Given this list of marker genes CRHBP, ACOX3, GBP4, CDCA7L, PDCD4-AS1, SVIP, CYFIP2, LAPTM4B, DNMT3B, MSH2, TRBC2, LRRC61, MAP4K2, PIGQ, GMDS-DT (NCBI Gene Id 100508120), RASD1, APP, LINC02573, MED9, NUP107, MZB1, EXT2, JUP, ACTR6, PDE7A, HOXB4, ADGRG1, KCNN4, ACAP1, TASP1, RAB37, ERMP1 (endoplasmic reticulum metallopeptidase 1), CD82, PTPRCAP, ARHGEF3, TRIM32, OXLD1, TMEM38B, HLF, PBXIP1, GPR146, HDAC7, TEX30, CXXC5, PRSS2, GABPB1-AS1, CD200, UMPS, CD34, PRORP, ZNF212, H2BC7, NOP2, USP20, SLC9B2, PFKP, ELP4, BEX2, ZNF23, CYYR1, ACOT2, ISYNA1, SLC39A8, ZNF74, SATB1, BAALC, TSPAN2, GATA2, LRBA, CD3E, MMRN1, ZNF738, PIGU (NCBI Gene Id 128869), LCK, PRKCQ, GIMAP2, MRPS27, TIE1, ALKBH4, CYTL1, FAM216A, H3C10, NDUFAF7, IGF2BP2, SPINK2, SYNGR1 (NCBI Gene Id 9145), TP53BP1, ANKRD28, CAMK2G, TMEM135, ZNF521, BCL11A, RRP9, ZEB1, MAGED1, C11orf54, KLHDC2, LRRC70, ANGEL1, TP53I3, IGHD, ADAT2, PXDN, ZNF254, CD7, MYB, EIF3J-DT, KLRG1, ACOT13 (acyl-CoA thioesterase 13), KPNA5, ZSCAN18, CD79A, MTMR6, SMARCAL1, ZNF493, MKS1, HOPX, STAP1, CMTR2, DVL2, TSPAN5, LINC00665, HMGA2 (NCBI Gene Id 8091, high mobility group AT-hook 2), TBCC, MSMO1, EFNA1, BCAS4, C1QTNF4, TFPI, NFE2, SEPTIN1, TMEM200A, GNAI1, MTRFR, ZNF444, TBC1D10C, AUTS2, RBPMS, SNHG21, ALDH1A1, MAST4, TARBP1, IPO11, EBPL, STRBP, H2BC11, CD109, TNFSF8, TRH (thyrotropin releasing hormone), KAT6B, STARD9, IGF2BP1, MDK, TIMP3, SETD1A, SLC25A51, ZNF100, ANGPT1, NT5C3B, CAVIN1, HACD1, AP1G2, NTHL1, ITM2A, STK26, RAMP1, ID3, TMEM106B, GNL3L, SELENOI, CLEC2D, SNRPN, CHST12, SAMD3, EMCN, GLMN, TMEM254, SPAG16, NPR3, PRKD2, ACBD6, MATK, NUCB2, KRBOX4, FHL1, CSGALNACT1, ARMH1, FHIP2A, SPTBN1, DPH5, KCNQ1OT1, ABHD4, RPRD1A, ADA, MLC1 (NCBI Gene Id 654039), STMN3, STIM1, SSBP2, ZNF576, MRPL45 (NCBI Gene Id 84311), BIN3, CSNK1G1, EPB41L4A-AS1, LMAN2L, TNFSF4, CREB3L4, PLAAT4, THEM6, INPP4B, OBI1, CLDN15, CRY1, IFT57, CLNK, KDM5B, BDH2, ZNF302, SEPTIN11, MSI2, TRAF3IP2-AS1, CA8, GATA3, RGP1, NREP, HOXB2, CPXM1, ADPRM (ADP-ribose/CDP-alcohol diphosphatase, manganese dependent), CEP290, ERGIC1, MUL1, AK3, HTR1F (5-hydroxytryptamine receptor 1F), SERF1B, DCP1B, QTRT1, TESMIN, SMYD3, SMAGP, PTGDR2, KRI1, PM20D2, PHGDH, CHRM3, RPP40, CSTPP1, MED21 (mediator complex subunit 21), DBN1, SERPING1, SPATA2L, RHPN1, B3GNT2, FARSB, MEST, BCL2, RDH14, RCN2, PAM, OCIAD2, CD69, MPHOSPH9, ERI1, CEP70, S1PR4, TEC, BEND5, SS18, BEX3, DNMT3A, RNF220, SLC2A5, FAM30A, ZNF606, HARS2, CHD1L, UQCC6, CLIP3, ZNF512, LEF1, SUPV3L1, SUPT3H, VEZT, MSRB3, HSH2D, MFAP4, FAM228B, MEIS1, DPPA4, ODF2L, C4orf46, FCMR, CNST, ZNF574, PODXL2, TRBV28, SCMH1, CDK6, CBX2, VWA5A, CALCRL, ACY3, HEMGN, ABCD4, KIT, HCG18, EXD2, SCAI, TFDP2, CBX8, CRACD, DLK1, TTI1, C16orf54, CD79B, MEG3, INTS4, VPREB1, NDN, TMIGD2, LXN, GRAP, NKG7, ESAM, H2BC12, MYL6B, LZTFL1, RHOBTB3, CFAP68, ZNF506, TCTN1, MIB2, CAVIN2, PMS2, SCN3A, TRANK1, RAB13, RCN1, BRF2, PGAP2, GSTM2, MFAP2, FAM117A, FUT8, CUTC, GUCY1A1, SCO2 (NCBI Gene Id 9997), SLC17A9, PLCB1, HPGD, IMPA1, VARS2, ACSS1, ZSCAN12, CDCA7, NIBAN3, TRIM5, CCNB1IP1, ZNF44, NOG, SPOCK2, ZCCHC7, HOXA9, INTS12 (integrator complex subunit 12), PRKACB, TRUB1, ZNF711, PROM1, TOX, DNASE1, PTPN7, GNG11, MLLT3, SCRN2, TUBG2, BPNT1, ERG, USP11, SMIM24, IKBKE, MED17, LPIN1, SOCS2 (suppressor of cytokine signaling 2), MUTYH (mutY DNA glycosylase), TM7SF3, SULT1C4, RCL1, ZNF140, RHOH, SHQ1, SYTL1, ICA1, BET1, ATP2A3, JCHAIN (NCBI Gene Id 3512), ARID5B, POLR2C, UBR5-DT, XXYLT1-AS2, MTA3, CTSW, PTK7, SLC37A1, IGHM, RNF31, DNAJC18, MMAB, PRSS57, ZNF420 (NCBI Gene Id 338425), LTB, NIPSNAP1, TSC22D1, MRM3, CMBL, here is a description of the gene set: HSC/ELP studied in species Homo sapiens from publication He P, Lim K, Sun D, Pett JP, Jeng Q, Polanski K, Dong Z, Bolt L, Richardson L, Mamanova L, Dabrowska M, Wilbrey-Clark A, Madissoon E, Tuong ZK, Dann E, Suo C, Goh I, Yoshida M, Nikolić MZ, Janes SM, He X, Barker RA, Teichmann SA, Marioni JC, Meyer KB, Rawlins EL (PMID 36493756) Human Gene Set: HE_LIM_SUN_FETAL_LUNG_C2_HSC_ELP_CELL